The following is a description of a gene set: Reactome Pathway: Heme degradation part of: Metabolism of porphyrins This event has been computationally inferred from an event that has been demonstrated in another species.<p>The inference is based on the homology mapping from PANTHER. Briefly, reactions for which all involved PhysicalEntities (in input, output and catalyst) have a mapped orthologue/paralogue (for complexes at least 75% of components must have a mapping) are inferred to the other species. species: Mus musculus electronically inferred by orthology from the curated human pathway, and this is the list of marker genes: Abcc2 (ATP-binding cassette, sub-family member 2), Ugt1a1, Ugt1a5, Abcg2, Hmox2, Gsta3, Blvrb, Alb